The following is a description of a gene set: studied in species Homo sapiens Human fetal and adult hematopoietic stem cells (HSC) were obtained from fetal liver, fetal bone marrow (BM), and adult BM. These were injected into human fetal thymic implants in SCID-hu Thy/Liv mice (4-6 separate mice per HSC donor) and allowed to mature into single positive CD4+ (SP4) thymocytes over the course of 7-8 weeks. SP4 thymocytes from injected stem cells were subsequently sort-purified from thymic implants and gene expression was performed. Genes up-regulated in thymic implants from fetal liver versus those from fetal bone marrow. from publication Mold JE, Venkatasubrahmanyam S, Burt TD, Michaëlsson J, Rivera JM, Galkina SA, Weinberg K, Stoddart CA, McCune JM (PMID 21164017) Human Gene Set: GSE25085_FETAL_LIVER_VS_FETAL_BM_SP4_THYMIC_IMPLANT_UP, and this is the list of marker genes: ICAM2, TRPV2, KCNK12, KIAA0319L, PUS10, TBRG1, ZKSCAN8, MBTD1, ATXN10, AP1S2, PRKACB, NME2, GMPS, ARHGAP15, EIF3L, PRPF3, ATP5PO (NCBI Gene Id 539), CCT2, TOP3B, FXR1, NSUN6, SLC39A6, PPP1R11, UBE2N, RPL7L1, PRSS50, DMAC1, TP53INP1, GATM, PTPRO, NUDT5, ZNF629, PDE2A (phosphodiesterase 2A), SLC31A2, PPP1R21, SDHB, NSDHL, CSTF3, AP1G2, HPGD, LIMA1, MED22, RGS10, SH3KBP1, USP22, BTF3, LMAN2L, MICU2, LIN37, NAPSA, ADGRE1, DNPEP, HMGCR, HEXA, ITGA8, KIF22, PSMD6, BTBD6, NUSAP1, SPAG7, SPG11, HERPUD1, ULK2, USP30, CDCA8, NANS, RPL35, G6PD, EVI2B, SLC25A45, PIM2, TWF2, NOD1, RAD51, KNTC1, MMACHC, LTC4S, STAM, SLC25A13, PDZD11, POLB, IDH3G, TXNRD2, TPGS1, NAXE, PTMS, BLOC1S5, PDLIM2, NSA2, CCAR2, FKBP15, SLC25A10, EPS15L1, RGS18, TEX30, CCNA2, ITGB7, ARHGEF6, MRPL45, ALKBH8, NDUFAF1, H2AZ1, EEF1AKMT1, NUCB2, PCLAF, BCAT2, TUBB, PHKB, NADK (NCBI Gene Id 65220), DDX56, USP15, CAV1, LCP2, RPL32, MDP1, CYP4F3, CENPE, CD300A, UFSP2, UBE2C, EIF4B, ST18, ICA1, HNRNPLL, DOCK10, PIK3R5, C11orf54, TRPC4AP, PRIMPOL, FDPS, HDAC1, RIOX2, RFX7, SMPD5, SRP68, MRPS28, DNAJC2, PDIA3, DDX41, DIAPH3, ABHD14B, CDK1, ZNF124, STAC, UBAP2L (NCBI Gene Id 9898), GFM2, EXOC3, SKIL, RFXANK, EIF3K, SF3B2 (splicing factor 3b subunit 2), NECAP1, DET1, TM4SF5, ARHGAP30, AURKA, RACGAP1, EIF3E, ACAT1, MADD, CCNB2, RPL13 (ribosomal protein L13), FUT4, PSRC1, IMPDH2, ANKFY1 (NCBI Gene Id 57500), CKAP2L, GNG2, TIMM21, RAMP1, NOL7, REXO4, OMA1, ANG, SLA, MPP1, TEX15, DCPS, DHX57, RPL17, EXO5, PAFAH2 (platelet activating factor acetylhydrolase 2), PABPC1L, RPS19, SLC2A3, ARHGEF7, CCDC90B (NCBI Gene Id 60492), SRP54, ACOT7, LRRC41, CORO1A, SESN1, RIT1, VIPAS39, INKA1, STARD4, ARHGAP18, PRC1, ACTG1, SWAP70